Given this list of marker genes KIF3A, KCND1, TUBB1, TMEM267, CD5, THNSL1, B4GALT2, ZNF397, ABHD6, HSD17B7, PBX2, RNF186, CTBP2, ZNF17, CSF2RB, UBAP1, ICAM4, AKAP4, CLCN6, RAPGEF1, BVES, WNT5B, POR, PLEKHA4, NHSL1, CEBPE, PGLYRP1, BNIP3L, APEH, TNFRSF8, FGD4, CLCNKB, SEC31B, PITHD1, CKAP5, PRDM8, MAP1LC3A, CATSPERB, PTCRA, RASGRP3, INSIG1, SELENON, NUP43, SCGB1A1, SERPINB7, here is a description of the gene set: Human Gene Set: MODULE_448 Genes in the cancer module 448. studied in species Homo sapiens